The following is a description of a gene set: Human Gene Set: GOBP_SUCCINYL_COA_CATABOLIC_PROCESS species: Homo sapiens The chemical reactions and pathways resulting in the breakdown of succinyl-CoA., and this is the list of marker genes: SUCLG1, NUDT8, SUCLA2, SUCLG2, NUDT19, NUDT7 (nudix hydrolase 7)